The following is a description of a gene set: Human Gene Set: HP_ABNORMALITY_OF_SKIN_PHYSIOLOGY Any abnormality of the physiological function of the skin. Abnormality of skin physiology species: Homo sapiens, and this is the list of marker genes: TLR8, NCSTN, FOXC2, CLDN1, CAMK2B, IRF1, ZEB2, SLC29A3, LIG1, ALOX12B, SLC19A1, ELF4, SRD5A3, MPEG1, GTF2H5, RNF113A, IL17RA, PTPRC, NIPAL4, RRAS2, PIK3CG, IL12A-AS1, HLA-B, PIK3R1, KANSL1, CST6, LACC1, LMBRD1, MAP3K14, AARS1, MED12, CYP4F22, IPO8, HLA-DQA1, STAT6, GGT1, VPS33B, POLR3A, WIPF1 (NCBI Gene Id 7456), ALK, TGM1, NFE2L2, BLM, TRAC, SLURP1, OTULIN, OSMR, SMARCA2, MNX1, UBE2A, GJB3, STAT4, SCNN1A (NCBI Gene Id 6337), PLCG2, NCKAP1L, FERMT3, RNASEH2C, CTLA4, TNFSF4, ABCA12, PTPN22, PEPD, PLEC, IL10RA, CTNNB1, CDK10, GP1BB, IGHM, LAMB3, GJA1, RNF31, ACADVL, USP48, NFKB1, SLCO1B3, CBS (NCBI Gene Id 875), CASP10, FOXP1, PRMT7, ABCB11, TNIP1, SEC24C, CFI, EGFR, SLC30A2, HSD3B7, STING1, KRT5, POU2AF1, AGA, CCR1, BLNK, LEMD3, MIF, JAK3, SEMA7A, TMC6, ARHGEF2, CLPB, NSUN2, CIB1, PSEN1, FECH, IL31RA, FCGR2B, LIPA, CAST, RBM8A, LSM11, ERCC3, KLK11, GINS1, SASH3, RFX7, PSENEN, IL12RB1, RNASEH2B, IFNGR1 (interferon gamma receptor 1), C1QC, LRRC8A, MAX, BRCA2, AK2, CARMIL2, ZNF341, PRDM12, G6PC3, IL2RG, MPLKIP, BCL11B, SPIB, DOLK, MPL, HYOU1, CLTRN, UBAC2, COL6A1, HDAC4, SDR9C7, ZFYVE19 (NCBI Gene Id 84936), TREX1, TLR7, SULT2B1, NCF1, DNASE1L3, MVK, TJP2, MRTFA, KARS1, TNPO3, EPHB4, ERCC5, SP110, MMEL1, AP3B1, CD40LG, CD79B (NCBI Gene Id 974), CCDC47, CDH23, SH3PXD2B, PRKACA, FLI1, IL1R1, TAF1, UNC13D, IL6R, NEK9, GATA1, IKBKG, CARD14, CFTR, KIAA0319L, ABCC9, IRAK1, MMP1, JMJD1C, LRRC32, PMVK, MST1, RBCK1, HLA-DPA1, IL36RN, PERP, DNASE1, LDHA, RAC1, BTNL2, ANGPT2, POLE, SPP1, NCF4, WDR1, CYBC1, CLEC7A, PPOX (NCBI Gene Id 7440), KDF1, PCCB, IL1RN, TMC8, LAMA3, DDX41, UROS, RAF1 (NCBI Gene Id 5894), STXBP2, ARVCF (NCBI Gene Id 421), HIRA, NOD2, ZAP70, TBC1D2B, KIT, CORO1A, SLC39A4, NSMCE3, PIEZO1, PKP1, DOCK11, TP63, TET2, COX4I2, ASXL1, FCGR2A, EBP, HLA-DRA, CTSB, POMP, GJB2, SPTB, RNU7-1, HLCS, IGHG2, TCIRG1, SLC27A4, DOCK2, PGM3, WNT4, ATP2A2, TTC7A, BTK, TKT, DNASE2, CARD11, H6PD, IRF2BP2, CD79A, KDSR, IL6ST, ATRX, EDARADD, RNU4ATAC, RFX5, SAMHD1 (SAM and HD domain containing deoxynucleoside triphosphate triphosphohydrolase 1), RAG1, PTPN3, KLRC4, USP53, TGM5, POLD3, PPP1R13L, DCLRE1C, NLRP12, IRF5, IL6, PI4KA, LIG4, TGFB1, RNASEH2A, SAT1, CYBB, EXTL3, GNA11, ITGB4, CBL, MBL2, STAT5B, MCCC2 (NCBI Gene Id 64087), FDPS, RTTN, LBR (NCBI Gene Id 653311), CIC, AP1S3, KRT1, USP8, SIK3, TLR4, ADAM17, DSE, KRT17, TARS1, COL7A1, FGA, C4A, USB1, ARPC1B (actin related protein 2/3 complex subunit 1B), TPR, DIP2B, ADAMTS3, SCN10A, PNPLA1, BCKDK, GNB2, RREB1, NECTIN1, EPB42 (NCBI Gene Id 2038), PAPSS2 (3'-phosphoadenosine 5'-phosphosulfate synthase 2), CSTA, GPR101, ERCC2, AR, UROD, SLC6A19, PSMB10, MALT1, LYST, NFKB2, SPINK5, BTD, CR2, CD3E, BRCA1, FAM111B, SIN3A, STX3, LPIN2, AP1B1, IGKC, IKBKB, CD3D, GPNMB, MSMO1, SRP19, TFRC, IL7R, IL23R, ANK1, IFIH1, GPR35, CHST14, KRT10, EDAR, ECM1, IFNG, JAK1, SRCAP, FERMT1, STAT1, DSG1, LIPN, SCNN1G, LCK, HSPA9, NR1H4, AIP, CD247, IL10RB, FLT4, LZTR1, CERS3, STAT3, TNFSF15, HPGD, SPTA1, FGFR2, SUOX, MEIS2 (NCBI Gene Id 56908), TNFAIP3, GATA3, RUNX1, MORC2, IL12B, WAS, KNSTRN, ELOVL4, FLG, GSN, TBK1, RIT1, RELB, ARPC5, SMARCAD1, IL7, CACNA1G, PCCA, PGM2L1, BRAF, HR, TBX1, IGLL1, ESR1, LYN, FCGR3B, SMG8, LCP2, ASPRV1, POGLUT1, FH, NAXD, EPOR, CASP8, CD3G, STK4, IVNS1ABP, NCF2, CYP11B1 (NCBI Gene Id 1584, cytochrome P450 family 11 subfamily B member 1), CARD9, MYSM1, PSMB9, HLA-C, DOCK8, JAZF1, RBP4 (NCBI Gene Id 5950), RNU12, PIGA, PNPLA2, PSMB8, IL10, RFXAP, MECP2, RAG2, THPO, ADAR, ST14, TOM1, SEMA4D, MYD88, ATP8B1, LHCGR, SYK, SLF2, SLC39A7, SPI1, UFD1, NUP107, SCNN1B, ASL, CTSC, SDHA, SLC4A1, RIPK1, ROS1, XYLT1, GJB4, EPAS1, SLC17A9, SCN11A, IL12A, DSG4, GJB6, POFUT1 (protein O-fucosyltransferase 1), EPG5, TRAF6, IRAK4, HLA-DQB1, NRAS, RFXANK, SEC61A1, DPP9, RORC, AQP5, FLG2, HLA-DPB1, DSP, STX11, SBDS, UBE2L3, ITGAM, IGHG1, C4B, PAH, LAMC2, KRT14, FOCAD, FOXN1, ELANE, CIITA, TRAF3IP2, ATP7B, ITGA6, MSN, SLCO2A1, JAK2, CHD7, CCBE1, SRSF2 (NCBI Gene Id 6427), NAE1, UBA1, SDHC, CD28, PSMB4, ALOXE3, RMRP, MYO5B (myosin VB), ACP5, ADA2, FOXP3, GJC2, NFKBIA, BLK, SCN9A, TRPV3, ERCC4, NLRC4, ETS1 (NCBI Gene Id 2113), ERAP1, DCDC2, TEK, ARMC5, SDHB, CYBA, DRG1, CASR, GFI1, MBTPS2 (membrane bound transcription factor peptidase, site 2), MEFV, PSTPIP1, MVD, TOP3A, ABCB4, SOX5, PKHD1, UNC45A, LRP1, IL17RC, KIF11, PIK3CA, NR3C1, MIA3, XPNPEP2, TNFRSF1A, BLOC1S6, MAP2K1, PDCD1, LSS, H3-3B, ADA, TCF4, XIAP, C5, IKZF3, ZNFX1, PRF1, TP53, AUTS2, PIK3CD, KIF12, VIPAS39, HLA-DRB1, EDA, BANK1, TNFRSF1B, NLRP3, DHCR7, ZNF750, SREBF1, KRT74, KDM1A, C1QB, TBCK, IL2RA (NCBI Gene Id 3559), PRTN3, CDSN, PTPN6, CARS1, COMT, NAA10, AIRE, FAT4 (NCBI Gene Id 79633), SMARCC2, LGI3, MPDU1, EFL1, GNAS, PXK, MTHFD1, TRPM4, MLX, LRBA, TCF3, SLCO1B1, DNAJC21, GTF2E2, SHOC2, B4GALT1, PDGFRA, NBEA, ITGB2, IL17F, FAS